Given this list of marker genes Bmp4 (bone morphogenetic protein 4), Frzb, Taf10, Mesp1, Ggt1, Cps1, Pck2, E2f8, Wnt1, E2f7, Pck1, Itga2, Hhex, Smarcb1, Foxh1, Foxa3, Prox1, Cyp1a1, here is a description of the gene set: The process in which a relatively unspecialized cell acquires the specialized features of a hepatocyte. A hepatocyte is specialized epithelial cell that is organized into interconnected plates called lobules, and is the main structural component of the liver. Mouse Gene Set: GOBP_HEPATOCYTE_DIFFERENTIATION species: Mus musculus